The following is a description of a gene set: studied in species Homo sapiens Human Gene Set: GOBP_SIGNAL_RELEASE The process in which a signal is secreted or discharged into the extracellular medium from a cellular source., and this is the list of marker genes: F2R, CCKAR, SYNJ1, ABCA12, P2RY1, UBE2Q1, VAMP7, SCG5, TFR2, GJA5, SYN2, JAK2, DOC2A, NLGN2, ILDR1, ADAM8, SYT12, GIT1, GPER1, DOC2B, IL1B, UCN, ANO1 (NCBI Gene Id 55107), RETN, TBX3, CADPS, PICK1, HTR2C, RAB11FIP2, GNA11, ABCA1, PTPN23, FOXO1, HIF1A, PIP5K1C, BRAF, VPS18, NMU, PDX1, SIRT6, SYP, SLC44A4, SMAD2, CPLX2, REN, SOX11, CXCL12, ADIPOQ, RAPGEF3, AQP1 (NCBI Gene Id 358), VAMP8, SELENOM, PPARD, SLC32A1, UQCC2 (ubiquinol-cytochrome c reductase complex assembly factor 2), TCIRG1, FAM3D, SNAP29 (synaptosome associated protein 29), UCP2, RIMS1, PINK1, PDZD11, TRPV6, BLOC1S6, LIF, KCNB1, SYNGR3, SV2A, STX2, SYT7, PRKCA, RAP1B, WLS, SYT1, HLA-DRB1, CDK5, EPHA5, FFAR3, PSMD9, ORAI1 (NCBI Gene Id 84876), GPR27, HNF1B, SLC25A22, HADH, SLC9B2, CPE, PPP3CA, MPC2, TUNAR, PRKCE, GNAZ, TFAP2B, MAFA, SYT11, TOR2A, F2RL1, FFAR4, HTR1A, KCNK16, GLUD1, PCSK5, PCK2, TM7SF3, STX19, GATA3, LRP5, F2RL2, PLA2G4A, GALR1 (NCBI Gene Id 2587), NGF, NADK, SYT5, RAP1BL, F2, RAB11FIP5, SYT10, JAGN1, EDNRB, CPLX3, SMAD4, ADCY8, ENSA, GHRHR, CHRNA4, KCNA5, TRPV4, PRKACA, UNC13B, KCNK9, LILRB1, NIBAN2, TARDBP, RPH3AL, APLN, MIF, ALOX5, ADCYAP1, LTBP4, SYN3, BRSK1, ACSL4, MYB, STXBP2, CYP19A1, RIMS3, ASIC1, ILDR2, HNF1A, RAB8B, CCL5, SYT9, STXBP1, NNAT, NMB, WNK4, DRD3, NPVF, ITSN1 (NCBI Gene Id 6453), OSBPL2, GRIK5, GABBR1, AP2B1, POMC, SNAPIN, SIRT4, SSTR5, REST, RAB44, UNC13A, GNAS, SNX6, RPH3A, CD38, CLOCK, ADORA2A, PRKCB, NR1H4, P2RX4, IL6, BEST1, MICU3, PTPRN, COMT (NCBI Gene Id 1312), ABCC8, CACNB4, KPNA4, TGM2, SNX4, ACVR1C, RIMS2, OSBP, KCNMB4, PLA2G3, NEUROD1, KLF7 (KLF transcription factor 7), KDM5B, SYT13, SERP1, SNAP47, RAB3A, EIPR1, EFNA5 (ephrin A5), CYB5R4, GPR151, INHA, PTPRN2, RFX3, TRPA1, MYOF, BLK, NPY2R, RBM4, NKX3-1, RAB11FIP3, NLGN1, GHRL, TPRG1L, GRM2, CRY1 (NCBI Gene Id 1407), CADPS2, C1QTNF1, CFTR, ERC2, RAPGEF4, SMPD3, PARK7, CAMK2A, FKBP1B, SLC30A1, PCLO, NAPA, GNAO1, STXBP3, RAB11B, PLA2G6, ABCC4, LRRK2, GDF9, SLC38A2, SNPH, LRRC8A, SYK, MCTP2, INS, HTR2A, STX11, SLC16A2, CHGA, CHRM3, FFAR2, PTGS2, STXBP5, SV2B (synaptic vesicle glycoprotein 2B), GNRHR, RASL10B, TACR2, PRRT2, VAMP2, NF1, PFKM, SNAP23, CELA2A, NPY, BAD, ADRA2B, GGCX (NCBI Gene Id 2677), ADORA1, PFKL, SV2C, BMP8A, SNCA, PIM3, GIPR, FGG, MCU, KMO (kynurenine 3-monooxygenase), KCNJ8, GIP, OPRM1, TACR1, GLP1R, OSM, LIN7A, NAPB, SLC2A2, STX4, TRPM5, ABAT, ISL1, ECRG4, IRS1, FGFR1, MTNR1B, TSPOAP1, PRKN, SREBF1, PTPN11, CREB1, SRI, MCTP1 (multiple C2 and transmembrane domain containing 1), CASK, GDNF, OTOF, DNAJC5 (DnaJ heat shock protein family (Hsp40) member C5), BTK, GPLD1, OXCT1, GNAT1, PLA2G10, SNCG, STXBP4, ANXA1, DAB2, SYT4 (NCBI Gene Id 6860), NRXN1, PRKCG, ENY2, NOS2, RBP4, NR1D1, NR0B2, CHRNB2, MYRIP, AACS, SYT8, FER1L5, SIDT2, MEF2C, RAC1, DYNLL1, OR51E2, RAB1A, CAPN10, IL11, GCK (glucokinase), ADORA3, KCNJ11, SYBU, FGB, C1QTNF12, MC4R, KCNA2, DRD2, RFX6, DTNBP1, TNFRSF11A, SLC16A10, SLC6A9 (NCBI Gene Id 6536), PFKFB2, PTGES (prostaglandin E synthase), SOX4 (NCBI Gene Id 6659), PNKD, ADAM17, SNCAIP, VIP, CRHR1, ADRA2C, GHSR, INHBA, RAP1A, FZD4, GRM4, ACVR2B, FGF23, G6PC2, PFN2, TCF7L2, CALM3, NPFF, EDN1, SLC16A1, ATP2A2, PER2, LEP, HRH3, IL1RN, C2CD2L, SYN1 (NCBI Gene Id 6853), CHRNA3, SLC18A2, PDE8B, FGF20, EDN3, CCDC186, SIRT3, FBXL20, AGT, CHRNB4, HTR1B, RAB11FIP1, IFNG, GPRC6A, PPFIA2, CHD7, CHRNA6, BMP6, CAMK2G, SNAP25, TNFSF11, SEPTIN5, FAM3B, MLXIPL (MLX interacting protein like), PRKAR1A, LIN7C, FMR1 (NCBI Gene Id 5421), FOXA2, FAM3A, WNT7A, LIN7B, SUCNR1, CCN3, CLTRN, C1QTNF3, NDUFAF2 (NCBI Gene Id 91942), SPP1, SLC8B1, GJA1, VSNL1, GRP, CACNA1B, P2RX7, EFR3A, GPR158, CRY2, STX1B, PLCB1, BMAL1, SLC6A4, PHPT1, MIDN, INHBB, RIMS4, DYSF, SLC18A3, SNX19, FGA, VPS35 (NCBI Gene Id 91808), GHRH, RAB5A, AIMP1, BGLAP, TMEM132A, HCRT, HFE, CDK16, GAL, EXOC3L1, VAMP3, OXT, VGF, CRHBP, BRSK2, CPT1A, ADCY5, P2RX1, GPR119, KCNQ1, GCG, SELENOT, PPFIA3, RAF1, PPP3CB, ADRA2A, CARTPT, FFAR1, FOXD1, UCN3, DVL1, OPRK1, SYT2, CRH, PAX8, TAC1, CPLX4, PRKD1, SCT, UNC13C, CPLX1, GPR68, TMF1, RAB3GAP1, PASK, FBXO45, GNAI1, ZBED6, SCRIB, FOXL2 (NCBI Gene Id 668), ITPR1, HNF4A, PORCN, STX1A, AGTR1 (angiotensin II receptor type 1), TSPO, HCAR2, SLC30A8, BAIAP3, NRXN2, HMGA2, LYN (NCBI Gene Id 4067), NKX6-1, SLC4A8, PPARG, CGA, IRS2, SYTL4, TRH, CSPG5, FCER1G, TRPM4, PPT1, CASR, TNF, PSEN1, PREPL